The following is a description of a gene set: Reactome Pathway: Formation of apoptosome The apoptosome is a cytoplasmic protein complex of two major components ‑ the adapter protein apoptotic protease activating factor 1 (APAF1) and the protease caspase‑9 (CASP9) which interact with each other through their caspase recruitment domains (CARD). The function of the apoptosome is to assemble a multimeric complex between APAF1 and procaspase-9 CARDs to facilitate CASP9 activation (Jiang X and Wang X 2000; Srinivasrula SM et al. 2001; Shiozaki EN et al. 2002). The apoptosome is assembled upon APAF1 interaction with cytochrome c (CYCS), which is released from the mitochondrial intermembrane space during apoptosis (Zou H et al. 1997; Yuan S et al. 2013; Shakeri R et al. 2017). CYCS‑bound APAF1 undergoes ATP-mediated conformational changes and in the presence of CARD of CASP9 oligomerizes into a heptameric complex, which activates procaspase 9 (Zou H et al. 1997; Bratton SB et al. 2010; Acehan D et al. 2002; Yu X et al. 2005; Yuan S et al. 2010; Su TW et al. 2017). In the apoptosome, recruitment of caspase-9 may occur before oligomerization in the CARD disk, which presumably brings the caspase domain into proximity for their dimerization and activation (Su TW et al. 2017; Hu Q et al. 2014; Cheng TC et al. 2016). Once activated, CASP9 activates downstream effector caspases‑3 and ‑7. The activated effector caspases then cleave various cellular proteins.<p> Different models have been proposed to explain CASP9 activation: the “proximity‑driven dimerization model” and the “induced conformation model”. The first models states that upon binding to heptameric APAF1, monomers of procaspase‑9 are brought into close proximity at a high concentration. This induces dimerization which is sufficient for CASP9 activation whereas autoprocessing within the apoptosome complex merely stabilizes CASP9 dimer (Boatright KM et al. 2003; Pop C et al. 2006). The “induced conformation model” is based on the observation that CASP9 has a much higher level of catalytic activity when it's bound to the apoptosome. The model suggests that a conformational change occurs at the active site of CASP9 upon binding to APAF1 thus inducing CASP9 homodimerization and stabilizing it in the catalytically active conformation (Shiozaki EN et al. 2002). CASP9 activation may also involve formation of a multimeric CARD:CARD assembly between APAF1 and procaspase‑9 (Hu Q et al. 2014).<br> species: Homo sapiens part of: Cytochrome c-mediated apoptotic response, and this is the list of marker genes: CASP9, CYCS, APAF1, MAPK1, CARD8, MAPK3, APIP, XIAP, UACA, DIABLO, AVEN